Given this list of marker genes Fdxr, Dicer1, Mir146, Nfe2, Asxl1, Fbxo4, here is a description of the gene set: Mouse genes annotated to increased myeloid sarcoma incidence (MP:0009439) retrieved from the Mouse Genome Informatics database via MouseMine Mouse Gene Set: MP_INCREASED_MYELOID_SARCOMA_INCIDENCE species: Mus musculus from publication Motenko H, Neuhauser SB, O'Keefe M, Richardson JE (PMID 26092688)